The following is a description of a gene set: Any process that activates or increases the frequency, rate or extent of response to wounding. Human Gene Set: GOBP_POSITIVE_REGULATION_OF_RESPONSE_TO_WOUNDING species: Homo sapiens, and this is the list of marker genes: HMGB1, SERPINE1, MIR221, CLDN1, XBP1, ANXA1, NTRK3, VEGFB, ACTG1, PUM2, MTOR, TMEM97, KANK1, MIR451A, HRG, ANO6, CLDN3, ST3GAL4, SCARF1 (scavenger receptor class F member 1), MIR29A, MDK, CD36, VTN, CCN4, OCLN, USF1, ADRA2A, DUOX2 (dual oxidase 2), PLAT, ARFGEF1, F3, MIR21, HBEGF, PTK2, MYLK, F2, TBXA2R, HTN1 (histatin 1, NCBI Gene Id 3346), FERMT2, MIR222, DMTN, GRN, REG3A, ENPP4, MIR431 (microRNA 431), CNTF, SERPINF2, DDR2, CLDN4, PRDX2, PRKCE, F7, DUOX1, THBD (NCBI Gene Id 7056), SMOC2, NFE2L2, F2R, FERMT1, EMILIN2, HRAS, PLG, FOXC2, F12, CLEC7A, HTN3, RREB1, INSL3, REG3G, ITGB1, THBS1, PTN, EMILIN1, APOH, BRAF, PLAU, HPSE